Given this list of marker genes CTNNB1, CRIPTO, RIPPLY2 (NCBI Gene Id 134701), MESP1, TMED2, BMPR1A, MDFI (NCBI Gene Id 4188), WT1, PKD1L1, CHRDL1, WDR77, TTC8, STIL, FGF10, AHI1, BMP4 (bone morphogenetic protein 4), C2CD3, PITX2, SIX2, TDRD6, PTCH1, LDB1, DCANP1, BASP1, PRICKLE1, DLL1 (delta like canonical Notch ligand 1), FUT6, NOTCH2, AXIN2, AXIN1, GDF3, WNT8A, VAX2, TDRD1, TASOR, FRS2, WNT5A, CER1, TBX6, EPB41L5, SMO, GPC3, WNT6, PLD6, NCKAP1, SKI, FOXA2, CITED2, LHX1, ARL13B, SETDB2, TDRD5, CDX1, FZD5, SMAD2, WNT3, SFRP1, CDX4, SRF, SMAD4, NRARP, IFT25, BCOR, TBXT, WNT7A, TIFAB, TDRD7, TBX3, WNT1, NEUROG1, ETS2, HEY2, RIPPLY1, HOXD8, IRX4, TDRKH, NODAL, LEFTY2, CXXC4, PCSK6, COBL, SHH, IFT172, PAX6, PGAP1, LEFTY1, CDX2 (NCBI Gene Id 1045), AURKA, MESP2, ZIC3, NOTCH1, RNF2, SIX3, STC1, OTX2, MNS1, SMAD6, WLS, CAPRIN2, DDIT3, here is a description of the gene set: Human Gene Set: GOBP_AXIS_SPECIFICATION The establishment, maintenance and elaboration of a pattern along a line or around a point. species: Homo sapiens